Given this list of marker genes SIRT2, CRYL1, SIRT3, GLUD1, HADH, PARP14, SIRT4, PARP15, HPGD (15-hydroxyprostaglandin dehydrogenase), HADHA, SIRT6, SIRT5, EHHADH, ZC3HAV1, SIRT7, UXS1, PARP9, SIRT1, ALDH1A3, here is a description of the gene set: species: Homo sapiens Human Gene Set: GOMF_NADPLUS_BINDING Binding to the oxidized form, NAD, of nicotinamide adenine dinucleotide, a coenzyme involved in many redox and biosynthetic reactions.